Given this list of marker genes ADCY6, ADCY3, LPAR4, ADCY9, ADCY2, RPS6KA5 (ribosomal protein S6 kinase A5), PRKACA, ADCY1, ADCY7, GNAL, ADCY4, ADCY5, CREB1, PRKCE, ADCY8, here is a description of the gene set: Human Gene Set: PID_LPA4_PATHWAY from publication Schaefer CF, Anthony K, Krupa S, Buchoff J, Day M, Hannay T, Buetow KH (PMID 18832364) species: Homo sapiens LPA4-mediated signaling events